Given this list of marker genes Hip1, Flot2 (flotillin 2), Clock, Nf1, R3hdm2, Tram1, Lyrm1, Dgkk, Limk1, Rem1, Nmnat2, Gas7, Ran, Zfp219, Bco2, Me3, Rhbdd1, Ubtf, Med17, Psd3, Git1, Xlr3c, Selenop, Pde1c, Phf2, Exosc1, Fiz1, Pygm, Prdm15, Sypl2, Hsd3b6, Zfp267, Caln1, Kirrel3, Myrf, Loxl3, Xlr3b, Tbata, Luzp1, Dnmt3a, Cpsf7, Olfm1, Shisa7, Ptprd, Greb1l, Apoa5 (apolipoprotein A-V), Trim26, Sardh, Il12a, Gpsm1, Slc16a2 (solute carrier family 16 (monocarboxylic acid transporters), member 2), Chrna4, Rnf13, Triml1, Nr1d2, Jade1, Rab19, Ncoa2, Cyfip2, Eif2ak1, Rimklb, Slc35f6, Shank3, Mbd6, Ppp2r2b (NCBI Gene Id 72930), Ift46, Aldh2, Ddx41, Dpys, Ahrr, Tirap, Hectd3, Tnfrsf1b, Nherf2, Vat1l, Lax1, Moap1, Xlr3a, Csnk1a1, Nectin2, Drc7, Fadd (Fas associated via death domain), Idua, Nos1, Dcaf1 (NCBI Gene Id 321006), Haus5, Ppp1r16b, Zfp606, Igf2, Cxcl17 (NCBI Gene Id 232983), Ago1, Pabir2, Camk1d, Ctdsp1, Nemp1 (NCBI Gene Id 72243), Lzts3, Stim1, Spred2, Clec4a1, Tspan11 (tetraspanin 11), Hsd3b3, Vat1, Tmt1b (thiol methyltransferase 1B), Camta1, Cacna2d2, Nsg2, Plcxd2, 4930524B15Rik, Elavl3, Trpc5, Bmp8b, Capn5, Dmkn, Cplx2, Ccdc97, Tom1l2, Atp2b1, Wnk4, Kif2c, here is a description of the gene set: Mouse Gene Set: MIR_8093 species: Mus musculus Genes predicted to be targets of miRBase v22 microRNA mmu_miR_8093 in miRDB v6.0 with MirTarget v4 prediction scores > 80 (high confidence targets). from publication Chen Y, Wang X (PMID 31504780)